The following is a description of a gene set: studied in species Homo sapiens A developmental process in which a progressive change in the state of some part of an organism, germline or somatic, specifically contributes to its ability to form offspring. Human Gene Set: GOBP_DEVELOPMENTAL_PROCESS_INVOLVED_IN_REPRODUCTION, and this is the list of marker genes: BTBD18, ROPN1B, SEBOX, OSR1, LIF, FAM50A, YTHDC1, CFAP61, ACE, PTGDR, WIPF3, AREG, ZCWPW1, SSH2, TSSK3, ICA1L, GGT1, IFTAP, FER, PRDX3, SSTR1, SEMG2, ZNF449, SRY, PRPS1L1 (NCBI Gene Id 91802), GREB1L, CATSPER1 (NCBI Gene Id 117144), IFT81, ROS1, SLC22A14, ZMYND12, CGA, SYNE1 (spectrin repeat containing nuclear envelope protein 1), NR5A2, WDR19, NKX2-1, SPEF2, DAZ3 (deleted in azoospermia 3), ZNF830, ZNF296, SPO11, CUL4A, AR, ABHD2, DEDD, CCNY, HEXB, GJA1, POC1A, NR2C2, PCYT1B, RBP4, RAB13, CBX2, TGFB2, BIRC3, MAST2, SPAG16, STK3, IQCG, SPATA31D4, ARID4A, PYGO1, FOXJ3, AMHR2, TSPY9, SELENOF (selenoprotein F), HSF2, CELF4, CCDC42, PGAM2, RIMBP3C, PLA2G3, MEIOSIN, TBC1D20, ACRV1, CDKL2 (NCBI Gene Id 8999), NKAPL, DCAF17, TEX15, AMH, INHBB, FBXW11, CIB1, KHDRBS1, ROBO2, ADAMTS2, ING2, TIPARP, GTSF1, MCIDAS, CATSPERD, PATZ1, AGFG2, MERTK (MER proto-oncogene, tyrosine kinase), RARG, ALPL, SMARCA2, MSH6, TTC12, HSPA2, FGF8, SIX3, YTHDF2, FANCA, TMPRSS12, PAIP2, PRDX4, GARIN3, EED, TCP11X1, TLR9, TDRD1, SPATA25, EHMT2, DDB1, OVOL1, NASP, E2F7, CYP17A1, BRCA2, PAQR7, VIPAS39, DHX36, SPMAP2, BBS2, BCL2L10, FST, REC8, IRX5, RXRB, GORASP2, DPY19L2P2, DMRT1, PLK4, EIF2B2 (eukaryotic translation initiation factor 2B subunit beta), NLRP14, SOX17, GHRL, RBX1, INSR, LRGUK, GPX4, UBE3A, OAZ3, ZSCAN21, PITHD1, DHH, STAT5A, ADAM7, BMPR2, HSD17B3, ADAMTS1 (NCBI Gene Id 9510), WT1, CEP57, SCX, SOHLH1 (NCBI Gene Id 402381), PRM1, RSPH6A, CELF3, TRIM27, PRKDC, SLC2A14, FSHB, TTLL8, TSPY3, TSSK4, NIPBL, C14orf39, HYAL3, DRC1, OOSP2, OCA2, SPATA31A7, SERPINA5, UBR2, FGF9, CYP26B1, FNDC3A, TOPAZ1, SOX8, GNRH1, HOOK1, ACTL9, SPATA19, SIRT1 (sirtuin 1), ZFP41, SPATA6L, HSF1, SFRP2, LZTFL1, BAK1, CDY2A, CCDC182, MOV10L1, GAL3ST1, SPATA31E1, HADH, ETV5, SIAH1, FOXL2, FBXO5, SLC4A2, HERC4, CCDC87, TEX19, NUPR1, DNAJB6, NPM2, TPPP3, UMODL1, CCDC34, CBL, CADM1, PCDH11Y, PFN4, MDFI, FZD4, TUT4, IFT20, ANTXR2, CDC25B, TSNAXIP1 (NCBI Gene Id 55815), MDK, SLC26A3, ABCB1, NDRG3, DNAJC19, HSF2BP, ESR1, MED1, FAM209B, SPAG8, CYP19A1, ZNF628, RPL39L, RB1, STC2, CDKN1C, KAT8, RETN, GMCL2, TESK2, BCL2L2, PBX1, PLN, PTN, TDRD7, TAF7L, SPPL2C (NCBI Gene Id 162540), IRF2BPL, SLC19A2, LEP, H1-6 (H1.6 linker histone, cluster member), KRT19, TSPY2, CCNB1, CSNK2A2, GK2, SNAI1, BMAL1, SPATA31A6, PTX3, RGS2, E2F1, TRIM28, C3orf62, ADCYAP1R1, IQCN, RNF114, CCDC63, GGNBP1, SPMIP7, HSF5, B4GALNT1, UBE2J1, HOXA13, SRD5A2, NSUN2, IFT56, CALR, HSD17B4, TSPY4, SUN5, UNC5C, JAG2, SPATA16, DEFB1, MYBL1, DNHD1, CDY2B, ALOX15B, SPACA1, TCF23, MGAT4D, SPACDR, FOXJ1, PGM3, SOX30, CABS1, KIFC1, DLD, BPY2B, SENP2, MFSD14A, DLEC1, CHN2, SERPINF1, SMARCC1, ACOX1, BSG, BTG1, TP63, B4GALT1, SEPTIN12, CFAP119, CEP128, SPDYA, ADAM29, SPAG11B, ACTL7A, ZBTB16, CHD7, SLC9C1, NDC1, YBX3, KMT2D, CDKN1B, TESC, TTC21A, USP42, MLH1, STRBP, RACGAP1, GLI1, MYCBP, ATP2B4, PDCL2, IQCF1, ZNF541, CNTLN (centlein), SPEM3, REC114, HOXB13, MORC1, SEPTIN4, DDX6, ANGPT2, IGF2R, CYLC2, TGFB1, IFT27, TXNDC8, WDR48, COL6A1, GARIN1B, NCOA1, ASB1, CCIN (NCBI Gene Id 92435), STXBP1 (syntaxin binding protein 1), FOXF2, AFP, MROH2B, REN, NDN, UTP14C, KIT, HNF1B, DUSP13B, CATSPER4, RRM1, ODF2, CT55, SKIL, ZPBP2 (NCBI Gene Id 124626), ODF1, SPMIP6, NICOL1, DNAH1, NDP, CREM, SFRP1, SHISA6, CYP27B1, H2AX, GMNC, ZFPM2, LHX9, STRA6, CEP131, H1-9P, AGFG1, YTHDC2, TMF1, AFG2A, CHD5, SULF1, CLOCK, HOXD13, HESX1, TSPAN8, BCAS2, EIF2B5, SEPTIN2, MAMLD1 (NCBI Gene Id 653998), DPY19L2, TMED2, AKAP4, IMMP2L, ADAM15, TDRD12, DEAF1, NOTCH4, VEGFA, CFAP91, WNT9B, SGPL1, KIF18A, TNP2, DND1 (DND microRNA-mediated repression inhibitor 1), MEIOC, EIF2S2, TUBB8, C3, CDY1B, PLAG1, DAZ1, FREY1, SPATA32 (NCBI Gene Id 124783), PDGFRA, SMAD5, NPPC, SSX1, KITLG, IHO1, TCP11, ATM, VCX, NEURL1, DHX37, PDE3A, NODAL, BPY2, TSPY8, PRLR, MOS, PRM3, CNTD1, HNF4A, CD2AP, METTL3, SPATC1L, GARIN1A, BCL2L11, RAC1, ROPN1L, BBOF1, ZAR1L, H3-3B, JAM3, NKX3-1, CITED2, STK11, PMFBP1, SCAPER, BASP1 (NCBI Gene Id 10409), BPY2C, CCDC146, BAG6, GHSR, SALL1, ADAM21, TAF4B, FRS2, NUP107, PRMT7, TESMIN, GALNTL5, SLC22A16, ROPN1, AGO4, CATSPERE, FLNA, TAF4, PPARD, DIAPH2, PTGIS, KRT9, BIK, GATA4, PROK2, ZFY, AP3B1, DAZ4, NME5, CCDC136, DCANP1, SERPINB5, SMAD4, NCOA4, CENPI, RIMBP3B, GAS2, ACVR1, PAQR5, EAF2, SLIT2, SPA17, CFAP221, AXL, TYRO3, AKR1C3, PANX1, RAN, MSH4, EIF4G3, SPATA6, ASH1L, YBX2, IHH, CABYR, SOX9, PRDM14, BCKDK, NPAP1, TCFL5, ODF4, TXNRD3, PARP2, SPATA31C1, CTSB, FAM9C, PLG, H3-4 (NCBI Gene Id 8290), CNBD2, GFRA1, SOX3, ACRBP, PRDM1, GDF9, NOS3, PRM2, RSPH1, PPP1R9B, CELF1, PIWIL3, SPATA31C2 (NCBI Gene Id 645961), EIF5A2, RPL10L, GDF7, METTL14, VPS54, SPATA2, LGR4, CCND1, SPP1, DMC1, CASP3, PAX5, PLEKHA1, SPATA31A3, TSPY1, PTPRN, RAD23B, MECP2, DDX20, NR5A1, INHBA, CFAP57, GGNBP2, PAEP, HOXA10, CIMAP1A, FAM9B, VGF (NCBI Gene Id 7425), TIFAB, TPPP2, ST14, TMEM232, CLDN11, LGR5, STRA8, ZFP57, PIAS1, VPS13B, INPP5B, MAJIN, TTLL3, NANOS1, SLCO4C1, FOXA1, FSIP2, PGR, ADGRG2, TESK1, CYP7B1, DMRT2, PMCH, CCR6, HOATZ, BMPR1A, ALKBH5, CREB3L4, PYGO2, YY1, SASS6, CATSPERG, AFF4, RPS6KB1, RUVBL1, HMGA2, GATA6, BCAP31, STK33, CTSH, MAP3K4, CAPZA3, STAT5B, DNALI1, COX7B2 (NCBI Gene Id 170712), DHCR24, CCNI, TBX3 (T-box transcription factor 3), TDRKH, FGFR2, ZC3H14, TCF21, PTCH1, GATA3, CYLC1, ADAD1, MEIG1, MNS1, CCNB1IP1, FOXJ2, MEA1, UPF3A, H1-1, CATSPER2, MKKS, ARMC12, OR7C1, FKBP4, MMP19, SLC26A8, PSAPL1, PRSS21, CSF1, LRRK2, YIF1B, GPR149, CCNO, DMRTC2, CNTFR (ciliary neurotrophic factor receptor), STOX2, RAB24, TGFBR1, BRD2, KATNAL1, IFT25, RARA, MAK, BMP6, SLC25A31, BAX, ACSBG2, GAMT, ADAM28 (ADAM metallopeptidase domain 28), C2CD6, CDY1, ZMYND15, SPATA31D3, NUP210L, DNMT3L, GMCL1, CFAP53, LRRC8A, MSH2, KDM5B, RPS6KA2, PTGS2, ASZ1, SUN1, TEX11, DAZAP1, TLE6, TLR3, CFAP52, SHB (NCBI Gene Id 6461), BOK, CTCFL, TNC, CFAP44, PTPN11, TMEM119, SPATA22, SPINT2, PARP11, TDRD9, H3-3A, GSK3A, HORMAD1, MYCBPAP, MEI4, FKBP6, TRIP13, PARP1, RFX2, SETX, UBE2B, CIBAR1, TARBP2, EFCAB9, RIMBP3, WFDC2, GGN, KDM3A, BRME1, PLD6, PKD1, TSSK1B, BNC1, TDRP, WNT5A, QKI, FAM9A, ADCY10, WNT4, ADIG, SFMBT1, PAFAH1B1, TSNAX, ARID4B, DMRTA1, BSPH1, LFNG, CDYL, ELSPBP1, VDAC3, CRKL, LHFPL2, DPCD, GJB5, ADAM2, INSRR, BMP5 (NCBI Gene Id 653), ANKRD49, CASP8, INHA (inhibin subunit alpha), PRKG1, EREG, SHCBP1L, SYCE3, KNL1, PDILT, SYCP2, TFAP2C, SPATA46, DLG1, NEURL4, LSM14B, WEE2, ID4, KRT8, USP26, RBM46, ADAM18, NOG, TCP11X2, DNMT3A, LIMK2, DAZL, NR0B1, DDX4, LHX1, CATSPERZ, STAU1, KLC3, ZGLP1, TERB2, LARP7, JUNB, RNF17, RHOBTB3, APOB, TSSK6, PIWIL1, E2F8, PANK2, GALNT3, ADGRG1, HMGB2, ZNF35, SPANXB1, INSL3, DMRT3, CFAP43, CFTR, RNF151 (NCBI Gene Id 146310), DDX25, PSMA8, CFAP47, SPATA20, SOX15, SIX4, ZSCAN2, PNLDC1, TSGA10 (testis specific 10), FEM1B, SIRT2, GCM1, MMP2, SEPTIN7, SPANXA1, CCNYL1, LRRC46, KDM1B, DCAF13, MYOCD, ATRX (ATRX chromatin remodeler, NCBI Gene Id 6475), CCNA1, PCSK4, CFAP65, LDOC1, LHB (NCBI Gene Id 3972), ZPBP, TUT7, TUBA8, BBS4, TTLL5, SLC9A8, OSBP2, LHCGR, SYCP1, NOTCH1, TTLL1, NOBOX, FOXC1, CRIP1, SYCP3, PPP1CC, DMRTA2, ARRDC5, CATSPERB, PUM1, CASP2, CTNNA1, SOD1, DYNLL1, PSAP, SEMG1, STAU2, SLIT3, AXDND1, SLC26A6, STC1, TPGS1, PRKAG1, GRHL2, TNP1, BCL6, SPAG4 (sperm associated antigen 4), CCDC62, SPAG6 (sperm associated antigen 6), TDRD5, ASPM, RAD51C, HAND1, ADAM20 (ADAM metallopeptidase domain 20), ERRFI1, EDNRA (endothelin receptor type A), ATP1A4, NANOS3, SPATA31D1, BCL2, POC1B, CCER1, DACH2, DRC7, SAFB2, IDH1, ARMC3, SPATA9, RHBDD1, PAFAH1B3, ELL3, IL1A, NTRK1, ARMC2, DACH1, ATAT1, MTA2, CNOT9, SIX5, EPC1, PAQR8, FANCE (FA complementation group E), KAT5, GARIN4, DNAAF3, KDR, CTCF, EPOR, LRP2, CFAP54, FANCG, TBP, FMN2, BOLL, PHC2 (polyhomeotic homolog 2), GATA1, ZAR1, CSMD1, UBB, TDRD6, CFAP157, SUFU, MORN2, SRC, WASHC5, HERC2 (NCBI Gene Id 8924), SERPINE2, SPAG17, PHB2, RNF8, BMPR1B, SPANXA2, PIWIL4, CRTAP, ZFP42, CFAP69 (cilia and flagella associated protein 69), ADGB, AZIN2, EDN1, NRIP1, MARF1, KASH5, MCMDC2, CSDE1, CFAP58, ELF5, SHH, TBPL1, MTOR, AKT1, NPHP1, MKRN2, IGF1, SRPK1, CFAP206, CBY3, TXNDC2, SPEM1, RBMY1B, KDM2B, CEBPB, RXFP2, SPATA31A1, TMEM203, MMP14, HOXA11, FSHR, FOXA3, KIAA0319L, FBXO24, CETN2 (NCBI Gene Id 812), WNT2B, WNT7A, DNAAF11, NR2F2, RNF2, SNRPA1, IZUMO3, SRD5A1, RNF38, NEUROG1, ERCC1, NHLH2, JAM2, STK4, BMP7, RAI14, SEPTIN14, ARID5B, NECTIN2, FIGLA, PPP2R1A, SBF1, PSME4, EOMES, SPINK2, CALR3, FZD5, ACVR2A, ATN1, DEFB118, LIN28A, BRDT, CDK16, ADAM32, KCTD19, PIK3CA, MYCN, ANG, HERPUD2, ADAD2, TBATA, DIRAS3, FXR1, TSSK2, MIR455, DMRTB1, FAM209A, TBC1D21, SPOCD1, CCDC38, BMP4, IGF2, IL1B, BRIP1, TLR5, TSPY10, TNFAIP6, CFAP97D1, PTTG1, SLIRP, MAEL, PIWIL2, NME8, KLHL10, PAFAH1B2, H2BC1, USP9Y, PRKACA, ODAD3, ASF1B, BCL2L1, ZDBF2, UTF1, NPR2, PACRG, CCDC159, PRKACG, DZIP1, CTNNB1, FUT6, H1-7, DAZ2, VDR, SPATA31A5, WDR77, SPINK1, WDR33, FOXO3, RDH10, FGF10, AURKA, CATSPER3, PRSS42P, SOHLH2, HOXA9, SEPTIN6, SPATA24, ZP3, NANOS2, ADAM30, M1AP, XRN2, EIF2B4